The following is a description of a gene set: Human Gene Set: WP_EICOSANOID_METABOLISM_VIA_LIPOOXYGENASES_LOX studied in species Homo sapiens Eicosanoid metabolism via lipooxygenases (LOX), and this is the list of marker genes: ACAA1, LTA4H, TRPA1, CYSLTR2, ALOX15, CYP4F12, CYP4F2, PTGR1, GGT5, PPARA, CYSLTR1, CYP4A22, LTC4S, LTB4R2, ACOX1, ALOX15B, DPEP1, ALOX12, PPARD, LTB4R (leukotriene B4 receptor), ALOX5, TRPV1, HPGD, ACOX2, EHHADH (enoyl-CoA hydratase and 3-hydroxyacyl CoA dehydrogenase), ACOX3, CYP4A11, FPR2, PTGR2